Given this list of marker genes LINC02380, FBXL2, COQ8B, MCC, ITGA7, APPL1, ESRP1, GGT7, DMXL1, RABL2B, CPAMD8, IPMK, STOML1, ZSCAN5A-AS1, HTN1, CCM2L, MCM8, HUWE1, PTGR3, GRN, NBPF11, SOCS4, LSM7, INF2, CFL2, PIEZO2, MXRA7, CFAP54, IL11, STRIP1, PENK, COL6A1, KIAA1217, TP63, CDK11B, MARCHF1, BUD13-DT, CYTOR, LRRC8A, JUNB, OGA, ENPP1, TTC38, THEM4, SMIM31, RNF138, MSI2, CSTF3, TM4SF4, PTPRE, KDM6A, MYO5C, VAMP2, SLC41A1, DUS2, TGIF2LX, HEATR3, TNFRSF9, TRUB1, SP100, XG, HYDIN, EFR3B, H2AC18, CEACAM6, TRPM8, GALR3, ENSG00000260832, PAK3, EDDM3A, METTL6, TCAF1, EPCIP, ACTR1B, MCL1 (NCBI Gene Id 4170), NOVA1, FAM83B (NCBI Gene Id 222584), PLXNA2 (plexin A2), MIR3142HG, LATS1, TGM4, FRS3, ENSG00000278932, DOCK9, CTAG1B, CCR1, ST13, MICA-AS1, CSH1, ARMCX1, DDX3Y, STON1, FBP1, NAV3 (NCBI Gene Id 89795), AKT3, KCNB1, ANLN, RAB1A, ORMDL1, RIMS1, PIH1D2, CHRNA2, DDX17, ZSCAN16-AS1, SMARCD1, RPS7, STON2, TBL1X, LMO4, GPN2, SPRR1A, SMAD3-DT, BID, VXN, PRPF8, TIMM17B, CRACDL, SNHG3, ABO, TMC5, RNF170, SEL1L2, KBTBD6, MAD2L2, LAT, BTF3L4, SEC23B, LAMTOR1, MLEC, CLEC7A, PPIL4, DPH3, TTC17, LNCATV, CACNB2, GPRIN1, STEAP1B (NCBI Gene Id 402466), RPS28, IL10RB-DT, FHAD1, ADGRD2, PSMF1, NAPEPLD, SYT17, FGL2 (NCBI Gene Id 10875), NDUFS2, HMOX1, FAM99A, CNTNAP5, CLDN6, CUL4B, TUBGCP6, TRIM6, CIB1, RREB1, JUND, RSPH14, MAP3K13, SUDS3, SMARCA2, CAMSAP1, CELF2, LINC02287, VCPKMT, OIT3, ZNF84, KIAA1143, BOC, RGS3, POM121L12, ATF1, TRAF3IP2-AS1, CHRM1, SMOX, CHMP4B, CXCR4, KRT72, BBS1, FAM242E, CSNK1E, PRIM2 (DNA primase subunit 2), SAP18, PRDM16, FNDC3B, LINC02239, GM2A, C1GALT1, SNU13, MTFR1, WDR1, TET2, FAM135B, NBEA, GID4, ENSG00000282375, STIM1, GOLGA3, PDZD8, BMP1, CHD9, NKAIN3, L3MBTL4, ABAT, KAT8, CNN3-DT, IKZF1, CYP2D6, IFT80, BRINP1, SPATS2, ERN1, FOSL2, UNC13A, RPL31P46, ALDH18A1, SLMAP, ENSG00000270174, MMP16, CROCCP2, SIAH1, GTPBP1, UBE2W, CAMK2N2, CLYBL, UBE2C, RFX1, TMCO1, MTURN, ENSG00000258168, HNRNPD-DT, ENSG00000291006, MYL4, CISD2, CEP70, WBP4, SRGAP3, MARS1, FAM181B, CDK12, NUP62CL, SERPINE2, H2BC10, ZNF276, ZNF891, SEC16B, SLC26A5-AS1, SLC35F6, TBC1D16, CEBPE, NLGN4X, CD93, AFF4, SSR1 (signal sequence receptor subunit 1), ABHD14B, AURKB, GOLGA6GP, B3GNTL1, SLC25A44, PPARGC1B, STEEP1, UBE2D1, RANBP6, PLEC, PSMG4, LINC00664, CSPP1, CNTNAP1, PRPF38B, ATP6V1C1, ENSG00000225420, TULP4, LKAAEAR1, GALC, GCDH, SLC15A4, CER1, SMIM7, WDR59, AFF2, ILRUN, RGL3, CEBPG, TBC1D24, SPEN-AS1, CPSF6, LINC01431, HGSNAT, EPHA4, MSRA, RABGAP1, GDF11, SMCO4, CACFD1, NUDT12, TUBA1C, LIX1, SLC38A11, MUC12-AS1, STRN, SLC1A2, SOX13, MTF2 (metal response element binding transcription factor 2), DDX54, ATP6V1F, WDR83OS, PTPRN2, PARPBP, USP30, APLP2, ADAM28, OVOL1, DCT, FIGN, LALBA, CAVIN2, ENSG00000238142, PIGF, ENSG00000274565, GARS1-DT, ACSL6, UFM1, HNRNPA3, LPP, ENPP6, SREK1, ADRA2A, SLC25A36, ATP6V0D1, CIZ1, RFESD, GPR199P, LINC00261, MBP, CHAD, FPR2, MAP3K2, CSF1R, FRYL, NUP98, PPP1R35, UQCR10, FOXD2-AS1, ZNF573, AGFG2, TEX36-AS1, ZFPL1, LTB, SLC28A3, SPATS2L, RUNX1T1, MRGPRX2 (NCBI Gene Id 117194), C15orf40, NUMA1, CBX3, USH1G, STX12, ONECUT1, RRP1, RFFL, HDC, KMT2A, LDLRAD4, YIPF5, FAM217B, RTP3, OR2B4P, ADAMDEC1, AK7, EPDR1, SLC15A3, RABAC1, NSD1, PGD, KLK10, TRAF3IP3, CERS5, LINC01016 (long intergenic non-protein coding RNA 1016), PLIN4, DUXAP8, PADI1, F7, SLC4A11, C5orf63, HUS1, ASPHD2, IFNAR2, ZNF117, IKZF4, SLC6A2, NAA16, GTF2H1 (general transcription factor IIH subunit 1), CD9, SOS1, ZDHHC17, CKS1B, NFASC, PCDHGC5, NDUFA11, FAM171A1, ZNF678, GLCCI1 (NCBI Gene Id 113263), SCN8A, LINC00582, BSN-DT, CCDC15, ZNF560, WIPI2, SNED1 (sushi, nidogen and EGF like domains 1), SLC25A30, FAM13B, LILRA1, PPP3CB-AS1 (NCBI Gene Id 101929145), NACC2 (NACC family member 2), SALL4, KIR2DS4, FAM83H, SLC7A6OS, FAM169A, AKIRIN1, TAT, GSN, TBX21, PAGE5, INSYN1-AS1, KBTBD7, ZCCHC10, RIF1, FMNL2, DCP2, MAP4K5, PALM2AKAP2, SH3TC1, C19orf44, NPNT, HIF1AN, IER2, RRN3P2, MIR99AHG, PPIC, PIGG, ANKMY1, HERC5, DMC1 (NCBI Gene Id 11144), LNPEP, RAP2A, MARCHF5, SPRYD4, KIF17, MYD88, here is a description of the gene set: CUG-repeat binding protein 1 (CUGBP1) mediates selective mRNA decay by binding to GU-rich elements (GREs) containing the sequence UGUUUGUUUGU found in the 3' untranslated region (UTR) of short-lived transcripts. We used an anti-CUGBP1 antibody to immunoprecipitate CUGBP1 from HeLa cytoplasmic extracts and analyzed the associated transcripts using oligonucleotide microarrays. We identified 613 putative mRNA targets of CUGBP1 and found that the UGUUUGUUUGU GRE sequence and a GU-repeat sequence were both highly enriched in the 3' UTRs of these targets. We showed that CUGBP1 bound specifically to the GU-repeat sequence and that insertion of this sequence into the 3' UTR of a beta-globin reporter transcript conferred instability to the transcript. Based on these results, we redefined the GRE to include this GU-repeat sequence. Our results suggest that CUGBP1 coordinately regulates the mRNA decay of a network of transcripts involved in cell growth, cell motility, and apoptosis. from publication Rattenbacher B, Beisang D, Wiesner DL, Jeschke JC, von Hohenberg M, St Louis-Vlasova IA, Bohjanen PR (PMID 20547756) species: Homo sapiens Transcripts bound by CELF1 in HeLa cells (cervical carcinoma). Human Gene Set: RATTENBACHER_BOUND_BY_CELF1